Given this list of marker genes MYOF, FKBP9, ATP11A, CDH5 (NCBI Gene Id 1003), MYO1C, WSB2, DDIT3, SON (SON DNA and RNA binding protein), ADD2 (NCBI Gene Id 130935), PGLYRP1, IL9R, MOV10L1, TBX4, TIAM1, CR2 (complement C3d receptor 2), DYRK1A, CHST10, IMPA2, MGAT4B, LETM1, PGLYRP2, GNB3 (G protein subunit beta 3), SLC35F6, LY75, DIP2B (disco interacting protein 2 homolog B), CD22, LSP1, TAGLN, PER3, ACTN1, CCDC90B, CWH43, QTRT1, SYT12, DGUOK, EEF1B2, AFG1L, YAP1, CCND2, TSPO, BPHL, TUBB2A, NIPAL2, KLHL10, TGFB2 (transforming growth factor beta 2), MEA1, TSR3, RAG1, TPRKB, IL17RD, CARD14, UMOD, CLDN8, ANGPT1, KIFC1 (kinesin family member C1), PKDCC (protein kinase domain containing, cytoplasmic), ANGPTL7, GSTO1, SCRT1 (scratch family transcriptional repressor 1), SLC26A6, MX1, KIF1A, PCOLCE, TAF10, PIGS, ZFP82, SETD4, MRE11, P2RY12, KLRD1, DPM2, PEX26, PLA2G15, CD34, NECTIN2, RNH1, DHX16, KRT20, CD79A, GUCY2C, S100A9, TMEM79, ENKD1, MFHAS1, BMS1, MFSD11, TDP1, TSKS, IZUMO1R, UBAP1, DSCAM, ADGRL4, CES3 (NCBI Gene Id 79984), FAAH, IRF8, CDK1, PTK7, ANKH, AHDC1, ZC3H3, ENPP2, H2AC25, GUCA1A, PCDHB5, SPTAN1, RCSD1, FAM50B, IMPG1, APOC3, SEPTIN2, GBP2, SORCS2, TTYH1, TMEM37, MICAL2, VAMP8, SLC6A13, LNX1, NAV2, DDX5, BEX3, SGMS1, FMC1, FOXI1, IFT81, CIITA, HLA-DMA, PGC, HBZ, CD209, TDO2, RTCA, OAF (out at first homolog), CHST7, MTSS1, SERPINA3, SMARCE1, KIF1C, VEGFB, VRK2, CCR6, HMGA1, CD200, LYPD8, NR5A1, DNM3, RPS8, N4BP3, PIP4K2A, CHRNA1, ANXA9, NCKIPSD, AMHR2, IL15RA, PKP3 (NCBI Gene Id 11187), CSF1, SLC5A11 (solute carrier family 5 member 11), TKFC, F8A1, CDH15, TPPP3, UBE2G1, SRF, KARS1, CLPP, SGCA, HAS2, PLA2G4F, CIB2, CLTB, POLG2, NSMCE4A, SHMT1, STXBP2, TKTL1, PHGDH, DUSP2, ANKRD33, CYYR1, POLG, TRPC5, HNRNPH3, CCL13, MAGEA11, THBS3, NUDT9, MYO5A, AAMDC, STAC2, SLC5A9, GAPDHS, RIPK2, IFNA1, ITM2B, BCL2L11 (BCL2 like 11), CC2D1A (NCBI Gene Id 54862), DCLK1, PSD, PFKP, CLCF1, here is a description of the gene set: mouse primary BMDCs were stimulated with tlr ligands and gene expression changes were profiled on Affymetrix arrays Genes up-regulated in comparison of dendritic cells (DC) stimulated with CpG DNA (TLR9 agonist) at 16 h versus DC cells stimulated with Gardiquimod (TLR7 agonist) at 16 h. from publication Amit I, Garber M, Chevrier N, Leite AP, Donner Y, Eisenhaure T, Guttman M, Grenier JK, Li W, Zuk O, Schubert LA, Birditt B, Shay T, Goren A, Zhang X, Smith Z, Deering R, McDonald RC, Cabili M, Bernstein BE, Rinn JL, Meissner A, Root DE, Hacohen N, Regev A (PMID 19729616) Human Gene Set: GSE17721_CPG_VS_GARDIQUIMOD_16H_BMDC_UP studied in species Homo sapiens